Given this list of marker genes SPP1, VEGFB, MT-CO2, VEGFC, TGFA, MMP2, PTGS2, VEGFA, MMP9, EGF, PLAU, here is a description of the gene set: from publication Agarwal A, Das K, Lerner N, Sathe S, Cicek M, Casey G, Sizemore N (PMID 15592509) Angiogenic and metastatic genes changed in RKO cells (colorectal cancer) upon perturbation of key components of AKT pathway. Human Gene Set: AGARWAL_AKT_PATHWAY_TARGETS Our laboratory has delineated that the phosphatidylinositol 3' kinase (PI3K)/AKT/I kappa B kinase (IKK) pathway positively regulates NF kappa B and beta-catenin, both important transcriptional regulators in colorectal cancer (CRC). Therefore, we investigated the effect of inhibiting the PI3K/AKT/IKK alpha pathway in regulating the inappropriate constitutive activation of NF kappa B and beta-catenin in CRC cell lines. SW480 and RKO CRC cell lines demonstrate constitutive activation of AKT as well as both NF kappa B- and beta-catenin-dependent transcription. The constitutive activation of NF kappa B- and beta-catenin-dependent transcription is inhibited by transiently transfecting either kinase dead (KD) IKK alpha, which blocks IKK alpha kinase activity, KD AKT, which blocks AKT activity, or wildtype (WT) PTEN, which inhibits PI3K and AKT activity. The ability of KD IKK alpha, KD AKT or WT PTEN to decrease beta-catenin-dependent transcription is independent of their effects on NF kappa B. Inducible expression of either KD IKK alpha or WT PTEN strongly inhibits both the constitutive NF kappa B- and beta-catenin-dependent promoter and endogenous gene activation. Targeted array-based gene expression analysis of this inducible system reveals that many of the genes downregulated upon inhibition of this pathway are involved in tumor angiogenesis and metastasis. The activation of this pathway and the expression of the three most repressed genes was further analysed in samples of CRC. These results indicate a role of this pathway in controlling gene expression important in tumor progression and metastasis. species: Homo sapiens